Given this list of marker genes DLC1 (DLC1 Rho GTPase activating protein), FERMT2, FLCN, ARHGEF16, SEMA4D, FLOT1, KANK2, GPR4, NET1, TAX1BP3 (Tax1 binding protein 3), ITGA3, MET (NCBI Gene Id 4233), ARHGAP35, RALBP1, CUL3, STARD8, SCAI, ARHGEF3, TNFAIP1, STARD13, ABL2, CCR7, PKP4, PDCD10, EPS8L3, ERBB2, MCF2L, DOCK9, STMN1, OPHN1 (oligophrenin 1), CCDC125, ARHGEF18, ABCA1, RAC1, COL3A1, EPS8L1, DOCK10, CDC42SE2, F2RL1 (NCBI Gene Id 7901), CSNK1A1 (NCBI Gene Id 55416), PLXNB1, LPAR2, DOCK8, CCL19, MYO9B, BCL6, ABL1 (NCBI Gene Id 25), DOCK11, ARHGAP30, AKAP13, CDC42SE1, ADGRG1, ARHGEF28, F2R, ARRB1, DOCK7, ARHGAP20, BCR, APOC3, ITGB1 (NCBI Gene Id 3688), TEK, KCTD13, F11R, PRAG1, MYOC, EPS8, RIT2, MIR223, SYNPO2L, EPS8L2, ABRA, ROBO1, FXR1, ARHGAP42, APOE, APOA1, KCTD10, ARHGDIA (Rho GDP dissociation inhibitor alpha), TAGAP, ARHGEF2 (Rho/Rac guanine nucleotide exchange factor 2), RIPOR1, HEG1, KANK1, MIR21, RAF1, RTN4R (reticulon 4 receptor), GPR55, RIPOR2, DOCK6, LPAR1, NRP1, RASIP1, ARHGDIB, ARHGEF10, here is a description of the gene set: Any process that modulates the frequency, rate or extent of Rho protein signal transduction. Human Gene Set: GOBP_REGULATION_OF_RHO_PROTEIN_SIGNAL_TRANSDUCTION species: Homo sapiens